The following is a description of a gene set: Genes predicted to be targets of miRBase v22 microRNA mmu_miR_12200_5p in miRDB v6.0 with MirTarget v4 prediction scores > 80 (high confidence targets). studied in species Mus musculus Mouse Gene Set: MIR_12200_5P from publication Chen Y, Wang X (PMID 31504780), and this is the list of marker genes: Senp5, Hapln1, Acsf2 (NCBI Gene Id 264895), Cnbp, Igfbp5, Sfxn3, Hoxd9, Crebzf, Fam227a, Ppp6c, Zfp329, Kmt2a, Ints12, Ift140, Slc15a1 (NCBI Gene Id 56643), Nap1l1, Dach1 (NCBI Gene Id 353035), Khdrbs2 (NCBI Gene Id 170771), Gpr12, Trmt9b, Samd8, Exoc5, Pcdh9, Ccdc34, Tbc1d30, Phf8, Bloc1s3, Synpo2 (NCBI Gene Id 99735), Zbtb7a, Pef1, Ddx39b (DEAD box helicase 39b), Rbm20, Gm20815 (predicted gene, 20815), Terf1, Gpat3, Fstl1, Wasl, Gfra2, Kcnk3, Fam3c, Nfib, Ranbp6, Mapk8, Mllt1, Sh3bgrl2, Naa16 (N(alpha)-acetyltransferase 16, NatA auxiliary subunit), Tgif1, Nuak2, Psd3, Slc10a4, Tpbg, Ldlr, Cox15, Tcstv5a, Ankrd13c, Rhobtb1, Zfand4, Naaladl2, Tet1, Lrrc58, Dyrk1a, Lsm6, Plcb3, Erich5, Klhl15 (NCBI Gene Id 76150), Arfgef1, Syt6, Herpud2, Vamp4, Slc35a5, Tmem88b (NCBI Gene Id 320587), Tent5a, Copb1, Hbegf, Elmod2, Fat1, Tm9sf3, Htr4, Speer4d, Cdh20, Gm5148, Bloc1s2, Onecut2, Zfp799, Mindy2, Jarid2, Zfp462, Aff2, Mier1, Bicd1, Ssh2, Hmgcll1, Sgk1, Ckap4 (cytoskeleton-associated protein 4), Fubp1, Zfp955a, Nbeal1, Rimbp2, Zmat1, Cds1, Ranbp3l, S1pr3, Lrrtm4 (leucine rich repeat transmembrane neuronal 4), Zfp719, Elf2, Rnf170, Fbxw7, Extl1, Xiap, Kctd12, Dnmt3a, Tcstv2a, Lnpep, Fign, Ercc6, P2ry4, Sntb2, Jade1, Phf14, Ctnnd1, Ctnna3, Ptpra, Ap3m1, Ccdc92 (NCBI Gene Id 52823), Ldlrad3 (NCBI Gene Id 98873), Prr7, Arih1, Gria3, Gmip, Naa12, Notch1, Preb, Sgcb, Ugcg, Msantd3, Iws1, Tdrd3, Creb1, Spryd7, Calml3, Marveld1, Trim6, Tcstv7a, Poldip3, Atrn (attractin), Foxo1, Nop16, Satb2, Tanc2, Cadps2 (NCBI Gene Id 320405), Ebf2, Dennd2c, Larp4, Celf2, U2surp, Champ1, Nhlh2, Kbtbd7, Snx11, Dcaf17, Mrfap1, Ccbe1, Wwtr1, Scfd1, Rplp0, Atl2, Gm5796, Cdc42ep4, Pcyox1l, Scn3a, Gna14, Adra1a, Zfhx3, Sgce, Zfp26, Oprm1, Ifnar2, Slc16a1, Chd9, Otud7b, Nfe2l1, Cutal, Jun, Lhx2, Sec22b, Dap3, Lrp6, 4921517D22Rik, Slc7a2, Zbtb21, Ttc12, Unc45b, Far1, Cebpg, Fpgt, Gngt1, Zfp92, Vps13d, Boc (NCBI Gene Id 212529), Ctnnd2, Piezo2, Gabrb2, Zfhx4, Prkaa2, Gm21083, Onecut3, Rere, Cyria, Ptpn2, Fosl2, Atxn7, Nfya, Gtf2a1, Gja8, Grk3, Slc10a2, Bcat1, Semp2l1, Ntng1, Lrrtm3, Tyms (NCBI Gene Id 22171), Zfp512, Tmed10, Bend4, Vezf1, Cd44, Prickle2 (NCBI Gene Id 77894), Mapk10, Cdc14a, Ccdc126, Zrsr2, Asb8, Dgkb, Cd55, Ddx3x, Psg16, Cflar, Ifnlr1, Adamts5, Vkorc1l1, Syt14, Poglut3, Sall1, Pogk (pogo transposable element with KRAB domain), Actr6, Fam187a, Ctso, Maml3, Mylk4, Cmtm6, Yes1, Prb1b, Parpbp, Braf, Dennd6a, Tbx3 (T-box 3), Rrp1b, Tbx18, Fgfr1, Epb41l2, Dars1 (NCBI Gene Id 319692), Trip12, Fcgr4, Cand1, Hccs, Wdr25, Armc2, Ythdf3, Kalrn, Zfp345, Gse1, Sgcz, Enah, Paqr9, Arid5b, Bcl2l12, Scn7a, Zfp422, Rora, Tbl1xr1, Polr3b, Neurod6, Tmem170, Fbxo3, Tmem263, Mgat2, Ppih, Cep15, Pou3f1, Unc13c, Dmrt1, E4f1, Cpeb2, Etv1, Zbtb44, Rab18, Scg2, Rbpj, Rnf4, Nfat5, Upf1, Cdk6, Faf1, Hsf5, Uqcc4, Hoxa10, Rab23, Nectin3, Adrb2 (NCBI Gene Id 269028), Serpinb10, Dgke, Scn8a, Hykk, Galc, D1Pas1, Tfap4, Fut9, Aebp2 (NCBI Gene Id 338513), Sec63, Reep3, Arid1b, Rmnd5a, Rab6b, Slc10a4-ps, Asah1, Rac2, Ttc6, Sirt6, Akap6, Lrba, Zfp654, Shisal2b, Stxbp6, Six4, Rnf44, Gpr158, Gm4894 (predicted gene 4894), Ereg, Ralbp1, Smc5, Gdpgp1, Tcp10c, Zfp113, Apol10b, Zmym2, Rflnb, Pex13, Zbtb41, Camk2a, Cdh2, Bdnf, Neu3, Nufip2, Cd200r4, Myt1l, Cxxc4, Satb1 (special AT-rich sequence binding protein 1), Gtf3c3, Syn2, Sin3b, Cxcr4, Fgf9, Plaur, Fthl17e, Impa1, Gm10375, Reep1, Shroom2, Trps1, Ddx46, Ppm1k, Casp3, Ddx19b, G2e3, Ccdc93, Sgms2, Ranbp1, Apbb2, Il1rap, Grm5, Smc6, Alg6, Rarb, Prpf18, Tfdp1, Fbxo43, Faxc, Fgf10, Fzd6, Zfx, Clcn5, Ppfibp1, Trim35, Matn1 (matrilin 1, cartilage matrix protein), Cep170, Gm5127, Prom2, Atp2b2, Ppp1r27, Septin8, Snrpb, Unc5c, Nip7, Gpm6a, Grb2, Afap1, Fbxo28, Ctsc, Scd4, Arhgap28, Tnrc6b, Glis3, Kpna2, Msi2, Camk2g, Kmt5b, Prdm1, Canx, Kdm1a, Prrg4, Mbnl2, Depdc1b, Apod, Pkp4, Hepacam2, Uri1, Plch1, Naa30, Tnrc6a, Ecm2, Ep300, Rest, Arrdc3, Dmp1, Pabpc5, Luzp2, 1700001F09Rik, Shisa9, Semp2l2a, Hipk1, Mrgprb2, Esyt2, Ddhd1, Gm8267, Tmed9, Ccnjl, Actc1, Aard, Tcstv4, Prtg, Slc35f1, Osbpl6, Sdr16c5, Eif2b1, Thbs2, Col19a1, Myod1, P2ry1, Tcf4, Myo1b, Selenoi, Akap5, Mdga2, Anapc1, Tsen34, Mvb12b, Nup107, Mia3, Bdp1, Szrd1, Cnot6, Runx3, Trim21, Aplp2, Mbtd1 (mbt domain containing 1), Zfp106, Marf1, Dusp10, Asb7, Paqr6, Arl13b, Kras, Mapk6, Htr1a, Mafb, Phtf2, Rsbn1l, Dicer1, Itsn1, Cnnm3, Med1, Rictor, Pank3, Bcl11b, Gab3, Foxp2, Pbrm1, Rai2, Ooep, Pcdhb19, Arhgap19, Washc4, Cdk7, Cyp2u1, Tcerg1, Fam53c, Sema3c, Ptf1a, R3hdm2, Rbm12, Cstf3, Tgfb2, Lonrf3, Samd4, Lclat1, Shisa2, Fthl17a, Get1, Entpd4, Znrf2, Zfand1, Nmt2, Tsc22d3, Plek, Zbtb37, Itpripl2, Prickle1, Chml, Ehf, Mllt11, Zfp84, Rabgap1, Zbtb26, Dynlt3, Yipf6, B4galt7, Tardbp, Il19, Septin7, Ptprf, Sash1, Bri3bp, Atp6v1a, Itgav, Adra2b, Tirap, Fbn2, Thsd7a, Slc25a51, Edem3 (ER degradation enhancer, mannosidase alpha-like 3), Zfp280c, Gm21190, Sgpp1, Kcnb2, Mast4, Osbpl8, Nlgn2, Tmub2, Hook3, Tceanc, Entpd7, Pcdhb22, Dnajc6, Zmym5, Slc25a46, Fndc3a, Abhd13, Irf2bp2, Snx12, Mageb3, Gpr22, Ptk7, Mef2c, Homer2, Hyal4, Eif5a2, Gm10377, Zfp503 (zinc finger protein 503), Snapc1, Cdk17, Ado, Irf1, Supt16, Socs4, Trim33, Hycc2, Acer3, Gsk3b, Wdtc1, Dpp8, Tcstv2b, Map3k4, Arl8a, Runx1t1, Ywhab, Parp11, Eml4, Med18, Metrn, Zfp518a (NCBI Gene Id 74010), Trim30a, Cbx5, Lgmn, Riok3, Pou2f1, Kdm5a, Sox5, Pbx2, Med12, Bcl6b, Zdhhc21, Timd2, Fkbp5, Nr6a1, E130308A19Rik, Map4, Hsp90aa1, Megf10, Nucks1, Bcl11a, Prelid3b, Phlpp1, Tspan31, Ap1g1, Deptor, Thumpd1, Fbxl14, Kif5c, Sycp3, Paip1, Dtwd2, Zfp292, Tasor (NCBI Gene Id 74444), Mex3a, Prkd3, Fsd1l, Cbln4, Zhx3, Pten, Azi2, St8sia4, Gpr107, Pcdhb16, Rpgrip1l, Fli1, Arl5b (ADP-ribosylation factor-like 5B), Orai2, Elavl1, Vsig10l, Myocd, Cts8, Synpr, Rorb, Celf1, Pcdh18, Ddhd2, Tfam, Bnip5, Septin11 (NCBI Gene Id 67780), Agl, Ttll7, Speer4e1, Mboat7, Skint7, Ythdc1, Ipcef1, Mtf2, Srgap1, Hps3, Ptpn21, Snurf, Glipr2, N4bp2l2, Slf2, Mtrr, Clock, Bend6, Gna13, Eif2s3x, Nat14, Macf1, Maoa, Tomm20, Dusp6, Abca8a, Pou4f1, St3gal4, Ran, Tenm2, Cpeb3, Cyp26b1, Slc8b1, Tcf7, Setx, Gbx2, Tcstv3 (NCBI Gene Id 236219), Elavl4, Ube4a, Rpusd2, Esrrg, Ssr3, Prkx, Pdcd10, Usp32, Hnf4g, Arb2a, Ccnd2, Tulp4, Tmppe, Luc7l, Ssx2ip, Scai, Zbtb34, Pde8b, Ubtd2, Pde4c, Elp2, Cbfb, Plekhm3, Hmgb2, Cpeb4, Arl5a, Utp4, Mllt3, Igf1, Cacna1c, Traf3ip1, Gpr183, Vwc2l, Fut11, Nras, Mrpl35, Ppp1cb, Speer4c1, Nrxn3, Il17re, Abraxas1, Kdm4a, Dstyk, Hspa5, Plaa, Mtcl2, Tcstv2c, Dtx3l, Twf1, Tmem87b (transmembrane protein 87B), Vav2, Zmat3, Crebrf, Hoxd11, Usf3, Ift80, Ino80d, Stxbp5, Psme3, Wnt5a, Csnk2a2, Tnpo1, Pafah1b1, Mphosph9, Cops7b, Cdc37, Dag1, Frmd4a, Smim13, Tmtc1, Adam17, Trim32, Noc2l, Pttg1, Dusp1, Ash2l, Slc22a23, Ct55, Csnk1a1, D16Ertd472e, Cacna1d, Cln8, Dcun1d3, Ythdc2, Tgfbr3, Syt15, Kcnh5, Map3k2, Mark2, Dock6, Trio, Lrrc38, Rb1cc1, Elovl7, Espnl, Pou3f2, Nab2, Cdh1, Kif1c, Sppl2a, Bclaf1, Tmx4, Hspbap1